The following is a description of a gene set: The chemical reactions and pathways involving organic acids, any acidic compound containing carbon in covalent linkage. studied in species Mus musculus Mouse Gene Set: GOBP_ORGANIC_ACID_METABOLIC_PROCESS, and this is the list of marker genes: Slc25a17, Fahd1, Amt, Apc (NCBI Gene Id 11789), Arnt, Tecrl, Extl3, Prodh2, Ddah1 (dimethylarginine dimethylaminohydrolase 1), Ehhadh, Adh6a, Sp1, Pla2g2a, Pdxdc1, Plp1, Elovl6, Cyp4a29, Acsm1, Gls2, Rdh10, Asah1, Xylb, Fabp5, Aspa, Bcl2l13, Pdzd11, Cyp1b1, Glul, Azin2, Cyp2c40, Cmas, Alox5ap, Cyp2w1, Mblac2, Slc25a44, Hal, Elovl5, Cyp27a1, Mpo, Upb1, Cyp2b10, Fahd2a (NCBI Gene Id 76488), Apoc1, Adh7 (alcohol dehydrogenase 7 (class IV), mu or sigma polypeptide), Pla2g4d (phospholipase A2, group IVD), Gad1, Cyp2d34, Prodh, Acsbg1, Cyp8b1, Agxt2, Ldhd, Ggt5, Ep300, Acad10, Nanp, Cyp4f14, Pcbd1, Acbd5, Ces2b, Sult2a7, Agmat, Ldhal6b, Htt, Ceacam1, Crabp2, Cyp3a44, Slc27a6, Ldhc, Hk2, Rdh16f2, Plin5, Slc16a1, Aass, Shmt2, Asrgl1, Gpam, Zbtb20, Akr1c18, Atp1a3, Cln3, Egln2, Gip, Cyp2d10, Snca, Acot2, Acaa1a, Acox1 (acyl-Coenzyme A oxidase 1, palmitoyl), Cbfa2t3, Abcc10, Fcer1a, Ppa2, Papss2 (NCBI Gene Id 74170), Pex5, Mapk9, Cyp2c67, Il4i1, Hacd2, Fabp3, Fbp1, Aco2, Ghr, Pparg, Gnpda2, Il3, Sult2a4, Adh6b, Acot3, Etfa, Mlxipl, Pex13, Bhmt, Pdha2, Npl, Cyp2c69, Acot12, Auh (NCBI Gene Id 97915), Iyd, Urod, Gart, Prkab2, Pla2g4a, Mccc2, Akr1b1, Acoxl, E2f1, Scd4, Fmo3, Slc27a1, Aldoart1, Arv1, Gstm6, Hk1, Hadhb, Abcb11, Htd2, Mecp2, Acot4, Gstm3, Cyp2u1 (NCBI Gene Id 71519), Tysnd1, Th, Them5, Cyp26b1, Cyp2r1, Me3, Hyi, Mdh1, Galk1, Ephx1, Gfpt2, Agxt, Sp7, Tecr, Tbxas1, Pnpla3, Adss1, Rac1, Erlin1, Mtarc2, Acnat1, Pdk4, Dld, Akr1c21, Phyh, Tat, Oat, Nudt8, Sik2, Pla2g5, Gnmt, Lpin3, Dbi, Dao, Sdsl, Ppat, Acsm4, Prkag2, Slc35a1, Igf1, Nans, Mcfd2, Prkaca, Degs1, Gstm1, Hao2, Got1, Acadl, App, Gne (NCBI Gene Id 69688), Trib3, Ptges3, Fkrp, Cyp2j5, Eno4, Cyp2c65, Me1, Nos2, Acbd7, Eno1b, Abhd2, Kyat1, Ptgr1, Apip, Pter, Cyp3a16, Slc27a5, Hdac4, Psat1, Apoc3 (apolipoprotein C-III), Slc38a8, Psen1, Amacr, Fgfr4, Tph1, Gpd1 (NCBI Gene Id 14555), Cyp4f18, Ces1d, Appl2, Nudt19, Slc22a13, Gck, Ppara, Aldh1l2, Esrrb, Aoah, Pnliprp1, Stat5b, Aldh5a1, Acadvl, Hpdl, P4ha1, Acsbg2 (acyl-CoA synthetase bubblegum family member 2), Apoa5, Edn2, Cyp2a4, Syk, Pnpla8, Pam, Asnsd1, Them4, Mif, Mdh1b, P2rx7 (purinergic receptor P2X, ligand-gated ion channel, 7), Tha1, Odc1, Clstn3, Rdh9, Bdh2, Phgdh, Cyp4a30b, Naalad2 (NCBI Gene Id 72560), Prxl2b, Scd2, Khk, Akr1c13, Sult2a8, Ero1b, Abcc1, Prdx4, Blvra, Carns1 (carnosine synthase 1), Aldoc, Cyp2c23, Gpx4, Aldoa, Ces2f, Glo1, Pecr, Cthrc1, Alox15, Pkm, Decr1, Pycr2, Hacl1, Abhd1, Lgsn, Nr1d1, Adipor1, Idh3a, Cpt1c, Oxsm, Hsd17b8, Lipe, Ucp2, Ugdh, Gulo, Hibadh, Pgd, Lpin2, Pla2g4f, Ces2h, Slc37a4, Rdh1, Pnlip, Tdo2, Pfkfb1, Ndp, Sucla2, Sult1b1, Bcat2, Abcd2, Aldh18a1, Abhd3 (NCBI Gene Id 106861), Mthfd1, Aldh3a2, Prkab1, Sult1e1, Tkfc, Me2 (malic enzyme 2, NAD(+)-dependent, mitochondrial), Eno2 (enolase 2, gamma neuronal), Reg3g, Acsf3, Gpat4, Spr, Mcat, Cyp2c39, Elovl4, Ggt1, Nit2, Ltc4s, Cyp2f2, Srd5a2, Pdk3, Cyp2j12, Prkag1 (NCBI Gene Id 19082), Acot1, Uroc1, Gstp3, Cyp2b23, Fasn, Fads6, Acad9, Eno1, Cyp4a12a, Baat, Dglucy, Ankrd26, Tyrp1, Ubr4, Cyp4a32, Kat2b, Mgat4a, Fpgs, Hagh, Nadsyn1, Sult2a2, C3, Hsd17b10, Cyp1a2, P4ha2, Atcay (ataxia, cerebellar, Cayman type), Ogdh, Cyp4f13, Tnxb, Ugt1a6a, Amdhd1, Hnf4a, Pfkp, Acot11, Aldh8a1, Hsd17b4, Zbtb7a, Atic, Gatm, Gclm, Irs2, Ces1a, Pla2g15, Pycr3, Ahcy, Ifng, Elovl3, Sephs1, Atp1a2, Pon1, Cyp1a1, Sult2a3, Mat1a, Acot7, Lipg, Icmt, Cyp26a1, Mgst3, Acat1, Hgd, Plod3, Idh1, Sesn2, Myc, Sirt6, Ido2, Pcx, Ncf1, Crat, Gpt, Ugt2a1, Ins2, Por, Trex1, Cyp2c50, Slc25a12, Acsf2, Col6a1, Arg2, Papss1, Acot9, Slc23a2, Hnf1a (HNF1 homeobox A), Elovl2, Nos1, Folr1 (NCBI Gene Id 14275), Aspg, Gba2, Echdc1, Scp2, Dpep1, Nr1h3, Acsm5, Slc39a8, Pipox, Adi1, Rbp1 (NCBI Gene Id 19659), Abcd1, Acss1, Bckdk, Atf4, Slc4a4 (NCBI Gene Id 54403), Cygb, Acox3, Hibch (NCBI Gene Id 98419), Pdha1, Pdk2, Gstp1, Ddit4, Sult1c1, Dct, Gcsh, Aldh1a2 (aldehyde dehydrogenase family 1, subfamily A2), Cyp2j13, Ptges2, Rgn, Qdpr, Mthfd2l, Arg1, Glyat, Pfas, Cyp2a5, Cyp2j11, Apoa4, Gnpda1, Acsl5, Pck2, Fabp4 (fatty acid binding protein 4, adipocyte), Cryl1, Xiap, Afmid, Ins1, Irs1, Fgfr1, Tnfrsf1a, Aldoart2, Ces1g, Alox12, Hoga1, Bhmt2, Aldh4a1, Cth, Fabp6, Thap4, Mtarc1, Cyp2c54, Erlin2, Abcc9, Plaa, Insig2, Comt, Acsbg3, Atp2b4, Ppard, Akt1, Pdhx, Pycr1, Cyp2b9, Ptgs2, St3gal1, Cyp2j6 (NCBI Gene Id 13110), Pklr, Prkaa2, Pank2, Mecr, Wdtc1, Sdhb, Aloxe3, Mapk14, Pdhb, Acadm, Faah, Vnn3, Klhl25, Adipor2, Renbp, Cyp2j7, Strap, Cnr1, Mtr, Adh4, Qki, Ddo, Pibf1, Sult2a5, Brca1, Ftcd, Selenon, Ces1c, Gcdh, Gapdhs (glyceraldehyde-3-phosphate dehydrogenase, spermatogenic), Aldh1l1, Lta4h, Mfsd8 (NCBI Gene Id 99720), Tlr4, Eci3, Elovl1, Prg3, Adh1, Slc45a2, Acads, Lypla2 (lysophospholipase 2), Cyp3a41b, Pemt, Ptges3-ps, Htr2a (NCBI Gene Id 239184), Pdk1, Lep, Stard4, Ldha, Gpt2, Ahr, C1qtnf2, Acot6, Dpep2, Lpgat1, Blmh, Gatd1, Bcl10, Cacna1a, Eif6, Slc5a6, Acsm2 (acyl-CoA synthetase medium-chain family member 2), Pex7, Azin1, Adtrp, Adpgk, Lonp2, Cyp2c55, Klf9, Cyp2d9, Cyp2ab1, St6gal1, Vnn1, Idh3b, Psph, Cdo1, Sgpl1, Cmah, Pla2g1b, Nfe2l1, Srebf1, Inpp4a, Cyp2s1, Avpr1a, Ppargc1a, Ptgr2, Acadsb, Mthfr, Ido1, Ces1b, Foxk2, Malrd1, Pgk1, Gstm7, Cpt1b, Plod2, Mfsd2a, Nr5a2, Acaa1b, Atp7a, Btd, Sirt1, Eci2, Cbr4, Hif1a, Lipc, Gamt, Alox12b, Cyp2j9, Suclg1, Pla2g2f, Cp, Ces2a, Decr2, Lpo (lactoperoxidase), Ech1, Bhmt1b, Cyp2t4, Cyp2a22, Akr1cl, Dbt, Ces2e, Tpk1, Prkag3, Abat, Prxl2c, Etfbkmt, Cyp39a1, Abhd5 (abhydrolase domain containing 5), Adss2, Trp53, Mrps36, Angptl3, Erfe, Sox9, Asl, Aldh1a1, Lipa, Akr1c19 (NCBI Gene Id 76349), Scd1, Gstm2, Lias (NCBI Gene Id 97216), Ppp2ca, Pah, Rdh16 (retinol dehydrogenase 16), Abcc2 (NCBI Gene Id 12780), Bckdhb, Gstp2, Cyp2c68, Mcrip2, Dcxr, Cyp2d11, Cyp4a10, Uevld, Src, Aco1, Hdc, Acad8, Aldh6a1, Cyp26c1, Srr, Gstp-ps, Acacb, Haghl, Carnmt1, Mpc1, Insig1, Oca2, Fah, Scap, Gcat, Tlr2, Sephs2, Cyp4a31, Naaa, Cyp2a12, Rdh19 (NCBI Gene Id 216453), Prmt3, Amdhd2, Mccc1, Fmo4, Bloc1s6, Gsta1, Cpt2, Crtap, Sord, Apoc2, Ass1, Apoc2l, Gclc, Acmsd, Pfkfb3, Shmt1, Mtln, Dbil5, Hadha, N6amt1, Grhpr, Mir214, Csl, Ncor1, Cyp3a11, Enpp1, Ero1a, Mrs2, Ivd, Acsl6, Cyp4a12b, Gadl1, Sdhaf3, Sphk1, Arl2, Cyp2d22, Atp8b1, Pfkm, Acly, Ldc1, Fmo1, Dhfr, Ttc36, Eno3, Gapdhrt, Mtor, Got1l1, Kynu, Vdac1, Ankrd23, Cyp4f40, Acox2, Daglb, Dpys, Actn3, Lipf, Myo5a, Cad (NCBI Gene Id 69719), Stat3, Slc27a3, As3mt, Pfkfb2, Anxa1, Enoph1, Nos3, Cyp2d12, Gsto2, Ilvbl, Pcbd2, Nr1h2, Peds1, Gsto1, Pm20d2 (peptidase M20 domain containing 2), Alox12e, Git1, Aldh1a7, Ephx2, Suclg2 (NCBI Gene Id 28021), Alox5, Mlst8, Hpgd, Kit, Cyp2c66, Ces2g, Sult2a1, Twist1, Scd3, Cps1, Ces1h, Pgam1, Cyp2g1, Pnkd, Slc7a11, Nucb2, Foxk1 (NCBI Gene Id 17425), Acaca, Gls, Sirt2, Cpt1a, Nr1h4, Lpl, Fads3, Abcd4, Aadat (NCBI Gene Id 23923), Sco1, Etfdh, Fads2b, Fgf15, Flcn, Aig1, Echdc2, Tigar, Slc2a6, Tpi1, Csad, Cyp2c38, Sds, Cyp2c37, Mid1ip1, Ddc, Mthfsl, Dhtkd1, Slco1a6, Hacd3, Per2, Adipoq, Alox8, Ces1f, Pgk2, Acot8, Acad12, Akr1d1 (aldo-keto reductase family 1, member D1), Insr, Fads1, Alkbh7, Ogdhl, Nudt7, Nupr1, Mpc2, Hsd17b12, Npc1, Jmjd8, P4hb, Mmut, Acot5, Ptges, St6gal2, C1qtnf9, Atp6v1b1, Crot, Ank, Cyp2e1, Cyb5a, Tmem135, Mir199a-2, Lypla1, Acsl4, Cd74, Prox1, Acnat2, Cav1, Cyp4v3, Ndufab1, Trim63, Slc7a7, Pgam2, Akr1c14, Fads2, Fabp1, Ugp2, Ugt2a2 (UDP glucuronosyltransferase 2 family, polypeptide A2), Fh1 (fumarate hydratase 1), Edn1, Mtch2 (NCBI Gene Id 80443), Nox4, Cs, Aasdh, Glud1, Dpyd, Cyp2c70, Idh2, Aacs, Pdpn, Gpx1, Txnrd1, Thnsl2, Hao1, Kyat3, Bin1 (NCBI Gene Id 30948), Pm20d1, Qprt, Ptgs1, Dagla, Cyp7b1, 4933405O20Rik, Echdc3, Pon3, Mdh2 (NCBI Gene Id 17448), Pla2g10, Olah, Hadh, Rptor, Uchl1, Cyp4a14, Acsm3, Oaz1, Asah2, Gapdhrt2, Pnliprp2, Nat8l, Prkar2b, Cbs, Acsl1, Gdf15, Uros, Pex2, Asns, D2hgdh, Slc1a3, Ceacam2, Eci1, Fa2h, Got2, Slc16a3, Aldob, Hkdc1, Akr1a1, Pcmt1, Ptgis, Gad2 (NCBI Gene Id 70758), Bpgm, Haao, Fmo2, Mpst, Acsl3, Slc38a1, Slc45a3, Mlycd, Tdh, Slc25a2, Star, Noxred1, Mri1, Hpgds, Ghsr, Echs1, Hacd4, Cyp7a1, Lpin1, Dlat, Ier3 (immediate early response 3), Ndufs6, Nagk, Dgat1, Akr1c6, Gstz1, Nags, Akr1c12, Idh3g, Pck1, Akr1c20, Ahcyl, Kmo, Park7, Prkaa1, Agt (angiotensinogen), Ces2c, Cyp4f15, Acat2, Stat5a, Ogt, Ucp3, Ptgds, Sult2a6, Mpi, Slc4a1, Dcaf5, Cyp2b19, Hk3, Hmgcl, Aasdhppt, Acaa2, Gk (glycerol kinase), Il1b, Cyp2d26, Aldh1a3, Ppm1k, Elovl7, Akt2, Bmncr, Sardh, Gldc, Gstm4, Bcat1, Sirt4, Cyp2b13, Acad11, Abcd3, Fabp2, Errfi1, Hlcs, Adhfe1, Slc27a2, Myog, Bckdha (branched chain ketoacid dehydrogenase E1, alpha polypeptide), Hpd, Scly, Gpi1, Tph2, Sdha, Etfb, Mgll, Mgst2, Eif2ak3, Galt (NCBI Gene Id 14430), Avp, Lcn5, Pfkl (phosphofructokinase, liver, B-type, NCBI Gene Id 18641), Mlx, Bco2, Csgalnact1, Dhrs9, Cyp3a41a, Hmgcll1, Mthfd1l, Slc27a4, Dgat2, Gale, Obp2a, Akr1b7, Pla2g3, Cyp2j8, Gapdh, Otc, Ces1e, Dlst, Mtrr, Cyp2c29, Adh5, Nmnat2, Hacd1, Acss2 (NCBI Gene Id 66135), Mtap, Ldhb, Sult2b1, Mthfd2